Given this list of marker genes Fgf10, Tifab, Neurog1, Ppp3ca, Trpc1, Aqp5, Negr1, Kcnn4, Chrm3, Oprk1, Tac4, Kcnma1, Chrm1, Aqp1, Slc4a9, Nkx2-3, here is a description of the gene set: species: Mus musculus Mouse Gene Set: GOBP_SALIVA_SECRETION The regulated release of saliva from the salivary glands. In man, the saliva is a turbid and slightly viscous fluid, generally of an alkaline reaction, and is secreted by the parotid, submaxillary, and sublingual glands. In the mouth the saliva is mixed with the secretion from the buccal glands. In man and many animals, saliva is an important digestive fluid on account of the presence of the peculiar enzyme, ptyalin.